The following is a description of a gene set: Mouse Gene Set: GOBP_RESPONSE_TO_TUMOR_CELL Any process that results in a change in state or activity of a cell or an organism (in terms of movement, secretion, enzyme production, gene expression, etc.) as a result of a stimulus from a tumor cell. species: Mus musculus, and this is the list of marker genes: Notch2, Pdcd1, Mr1, Ufl1, Ahr, Nkg7, Il12a, Dapk1, Xcl1, Abi3, Slc22a13, Klrk1, Cd40lg, Il12b, Cd274, Tgfb1, Rbms3, Klf4, Notch1, Cd226, Prdx2, Hrg, Gsdme, Kctd9, Igfbpl1, Havcr2, Prf1, Raet1d (retinoic acid early transcript delta), Prkaa1, Rela, Crtam, Plk5, Nectin2, Il4i1, Txnip, Ceacam1, Spi1, Pvr, Dlec1, Adam15, Hnmt, Hmgb1, Klhl22, Hspd1, Cd160 (NCBI Gene Id 99838), Ulbp1, Laptm5, Muc4, Ywhag, Mill1, Cd24a, Fbxo38, Klre1